The following is a description of a gene set: Any process that modulates the rate, frequency or extent of hydrogen peroxide biosynthesis. The chemical reactions and pathways resulting in the formation of hydrogen peroxide (H2O2), a potentially harmful byproduct of aerobic cellular respiration which can cause damage to DNA. Mouse Gene Set: GOBP_REGULATION_OF_HYDROGEN_PEROXIDE_BIOSYNTHETIC_PROCESS studied in species Mus musculus, and this is the list of marker genes: Fyn, Nox4, Duoxa1, Zfp13, Duoxa2, Ctns, Mfn2, Sod2, Stat3, Mpv17l